Given this list of marker genes HDGFL2, CHD5, CDYL2, CDY1, TAF7, LRWD1 (NCBI Gene Id 222229), CBX8, CDY1B, H1-2, TAF1, here is a description of the gene set: species: Homo sapiens Human Gene Set: GOMF_HISTONE_H3K27ME3_READER_ACTIVITY A histone reader that recognizes a histone H3 trimethylated at lysine 27.